Given this list of marker genes APPBP2, KCNE1, TSC1, EGR3, OLFML3, INSM2, SNX21, ACSM1, COL26A1, PBX2, VPS45, DEUP1, ZNF276, APLP2, CHRD, CHRNB2, CASD1, MAN1A1, FPGT-TNNI3K, GTPBP2, GNG13, SENP2, DDX19A, KIF21B, UTP25, ILRUN, NFE2L1, KCND3, CBLN3, AMPD3, TNNI3K, MAGOHB, SPINDOC, C6orf15, CORIN, TSKU, TNFAIP1, ZNF829, here is a description of the gene set: species: Homo sapiens Human Gene Set: MIR1296_3P Genes predicted to be targets of miRBase v22 microRNA hsa-miR-1296-3p in miRDB v6.0 with MirTarget v4 prediction scores > 80 (high confidence targets). from publication Chen Y, Wang X (PMID 31504780)